Given this list of marker genes SP110, GLS, CHEK2, CFB, ALAS1, COG5, MR1, GALK2, SLC31A2, SCO2, SLC1A3, RNF113A, HLA-DMB, PADI2, POMC, BLNK, PLPP3, ATP1B1, PLA2G4C, TERF2, IDO1, ST6GAL1, SLC20A1, ITM2B, ARAP1, ST3GAL5, ARHGAP5, UNG, TRAFD1, BBC3, JADE2, ATF6B, PRKX, HSD11B1, TBC1D2B, MT3, MTHFD1, PIM1, CD1D, PTK2B, HMGCL, TRAPPC12, MGAT1, PSMB10, SASH3, ANGEL1, MX1, STOM, IRAG2, TAP2, BRD3, SERPING1, ZRSR2, ZNF274, PEX14, FCGR1A, N4BP2L1, H1-0, ABHD5, VPS9D1, DTNB, TRANK1, NDUFV1-DT, IFI44, APOBEC3G, CCL18, FYB1, TGM2, CD33, NR1H3, AUH, DECR1, CREB5, TMEM109, TMEM131L, CXCL11, STAT2, ERLIN1, PTPN2, TREX1, PSMB9, CERS6, USP6NL, SCAMP3, ASH2L, GGCT, INTS9, APOL1, RIDA, OAS2, PPFIBP2, TRIO, IFI27, RERE, LEPROTL1, SLAMF1, UVRAG, EZH2, TTLL1, SORBS3, APEX1, PHKG2, GGH (NCBI Gene Id 8836), DDB2, FAM168A, SECTM1, LAMP1, VPS13B, IRF1, IVD, DOK1, SERBP1 (SERPINE1 mRNA binding protein 1), CUL1, CELF1, ITIH1, C2, VPS8, PCK2, AKR1A1, RRAS, FIG4, CXCL10, FZD2, CHI3L1, CSK, CD38, BTN3A3, ZMYND8, MPO, ZBTB11, ILK, WARS1, XAF1, SMPD1, FRAT2, WDR7, SPINT2, NAA80, DXO, RABGGTA, CLU, OGT, IL10RA, TNFAIP2, SEPHS2, CCRL2, ECH1, GNS, FGL2, SDC3, ATOX1, PLAAT4, SDHB, CTSC, HAX1, GM2A, PSMB3, TNFSF10, GBP1, ATIC, PHF21A, PLCG2, RFX5, VAMP5, GBP2, NADK, TAP1, KDM3B, C1S, RBCK1, IFI35, CXCL9, MTMR1, PSTPIP1, P2RY14, CKS1B, C1QB, DGCR6L, GCH1, PML, CFH, TADA3 (NCBI Gene Id 10474), TFCP2, POM121L6P, SDHA, XPO6, BBX, NDUFS2, IFI44L, ZMIZ2, RBP4, SLC6A12, XPC, SOCS1, ACP5, UBE2L6, NUCB1, MRTFA, STAT5A, here is a description of the gene set: Epithelial cells provide an initial line of defense against damage and pathogens in barrier tissues such as the skin; however this balance is disrupted in obesity and metabolic disease. Skin gamma delta T cells recognize epithelial damage and release cytokines and growth factors that facilitate wound repair. To determine the impact of obesity and metabolic disease on skin gamma delta T cells, we isolated skin gamma delta T cells from 10-week old C57BLKS/J lean db/+ and obese db/db animals for further study. Due to a deficiency in the leptin receptor (db), homozygous db/db animals do not process satiety signals, continually eat and develop severe obesity and metabolic disease. Skin gamma delta T cells isolated from these animals were compared for changes in mRNA expression using microarray. We have determined that obesity and metabolic disease negatively impacts homeostasis and functionality of skin gamma delta T cells, rendering host defense mechanisms vulnerable to injury and infection. Human Gene Set: GSE22196_HEALTHY_VS_OBESE_MOUSE_SKIN_GAMMADELTA_TCELL_UP Genes up-regulated in skin gamma delta T cells: healthy versus obesity. from publication Taylor KR, Mills RE, Costanzo AE, Jameson JM (PMID 20625397) studied in species Homo sapiens